The following is a description of a gene set: species: Homo sapiens There is much evidence that T cells may be activated via mechanisms which act independently of direct TCR ligation. Despite this, the question of whether such forms of ‘bystander’ T cell activation occur during immune responses is hotly debated. To address some outstanding questions, we set up an in vitro system within which to analyse bystander T cell activation in human T cells, in the absence of the possibility for TCR cross-reactivity. In addition, we have investigated the genetic, phenotypic, and functional characteristics of bystander activated T cells. Here, we show that bystander T cell activation is, indeed, observed during a specific immune response, and that it occurs preferentially amongst CD4+ memory T cells. Furthermore, bystander activated T cells display a distinct gene expression profile. The mechanism for bystander T cell activation involves soluble factors, and the outcome is an elevated level of apoptosis. This may provide an explanation for the attrition of T cell memory pools of heterologous specificity during immune responses to pathogens such as viruses. Genes up-regulated in comparison of resting CD4 T cells versus directly activated CD4 T cells. Human Gene Set: GSE13738_RESTING_VS_TCR_ACTIVATED_CD4_TCELL_UP from publication Bangs SC, Baban D, Cattan HJ, Li CK, McMichael AJ, Xu XN (PMID 19201849), and this is the list of marker genes: ZBED5, HBB, NKAPL, TMEM105, TSC1, TLE4, TRAM2-AS1, ZBTB20, LINC02092, RPS12, OCIAD1, GARRE1, SLC26A11 (solute carrier family 26 member 11), LRRC37A2, FAM13A-AS1, SLC33A1, PGF, TIGD7, AMIGO1, PATJ, MAX, SLC22A3, HS6ST1, KMT2C, ARHGEF15, ITGA6, XPO6, FCRL5, FAM13B, ZNF611, GCOM1, DBT, SECISBP2, MDM4, ZFP28, N4BP2L2, ATF7IP, GPRASP2, ZNF808, IFNGR2, ZNF582-DT, USP6NL, ENSG00000290941, HAUS3, C14orf28, PRKAB2, SLC35E1, STK38, TIGD1, EBAG9, CCDC93, PIK3IP1, GIMAP2, SH2D3A, FNBP4, PHC3, MORC3, RANBP6, MAP3K2, TUNAR, SORL1, TMEM63A, PLXNA1, CHCHD7, SLC44A3, DNAJC3, EREG, FAM171A1, APBA2, ANXA2R, GTF2H1, NR3C2, ZNF350, PCF11, SPEN-AS1, NDFIP1, SFTPB, GVINP1, LEPROTL1, LY9, COA8, POU6F1, AXIN2, ZNF160, NAP1L2, AGBL1, AFG3L1P, TSPYL2, GTSE1, FAM161B, SLC10A1, SLCO3A1, LINC01949, SCML1, NOL4L, SLC18B1, CCDC152 (NCBI Gene Id 100129792), ACSS1, CBY1, ZBP1, MINDY1, FOXH1, SETD6, NGRN, RSBN1, ZNF763, HNRNPDL, FAM117B, WDR37, ZNF232, ALS2CL, CMKLR2, KIAA0825, USP27X, BTN2A1, RIOK3, ABCD4, ZNF550, CHD3, ZNF767P, ADAM33, UNKL, RCBTB2, PRKD3, ATXN7 (NCBI Gene Id 6314), REV1, EZH1, MBNL3, EPHA4, ENGASE, ZNF204P, ZNF44, SLC40A1, TCEANC, TNFRSF10D, BICC1, ZMYM1, WDR19 (WD repeat domain 19), ASTE1, ELK4, JADE1, ACSM5, FAM118A, HCG27, SRSF7, FAM199X (family with sequence similarity 199, X-linked), SEC14L4, RICTOR, KLF2, TBL1X, TCP11L2, SNORD104, ZNF329 (zinc finger protein 329), KLF17P1, TNRC6B, MLXIP, MGAT4A, PREPL, TRAPPC2, QNG1, SYNJ2BP, LINC00528, HTRA4, BTN3A3, LINC01138, GPRASP1, FKBP4, PARP8, SUN1, IGF1R, TWF1, TSPAN9, CBX7, ZNF793, PRKAA2, MID1, ERN2, MATN1-AS1 (NCBI Gene Id 100290848), TAF4, ZNF502, PHF1, TMOD4, CELF1, LRRC8D, MTCL2, TSHZ1, LINC00574, VCPKMT, DCAF5, CDK20, SFTPC, CALHM5, KIDINS220, GPC2, TNKS